Given this list of marker genes E2f1, Ccna1, E2f3, here is a description of the gene set: electronically inferred by orthology from the curated human pathway Reactome Pathway: G2 Phase This event has been computationally inferred from an event that has been demonstrated in another species.<p>The inference is based on the homology mapping from PANTHER. Briefly, reactions for which all involved PhysicalEntities (in input, output and catalyst) have a mapped orthologue/paralogue (for complexes at least 75% of components must have a mapping) are inferred to the other species. species: Mus musculus part of: Mitotic G2-G2/M phases